Given this list of marker genes PDZRN4, LHX6, RBP1, FOS, PDE4DIP, DLX2, MAF, NXPH1, CXCR4, BRINP2, ARL4D, here is a description of the gene set: from publication Fan X, Dong J, Zhong S, Wei Y, Wu Q, Yan L, Yong J, Sun L, Wang X, Zhao Y, Wang W, Yan J, Wang X, Qiao J, Tang F (PMID 29867213) species: Homo sapiens Human Gene Set: FAN_EMBRYONIC_CTX_IN_1_INTERNEURON